The following is a description of a gene set: from publication Xie X, Lu J, Kulbokas EJ, Golub TR, Mootha V, Lindblad-Toh K, Lander ES, Kellis M (PMID 15735639) species: Homo sapiens Genes having at least one occurrence of the highly conserved motif M8 TMTCGCGANR in the regions spanning 4 kb centered on their transcription starting sites. The motif does not match any known transcription factor binding site. Comprehensive identification of all functional elements encoded in the human genome is a fundamental need in biomedical research. Here, we present a comparative analysis of the human, mouse, rat and dog genomes to create a systematic catalogue of common regulatory motifs in promoters and 3' untranslated regions (3' UTRs). The promoter analysis yields 174 candidate motifs, including most previously known transcription-factor binding sites and 105 new motifs. The 3'-UTR analysis yields 106 motifs likely to be involved in post-transcriptional regulation. Nearly one-half are associated with microRNAs (miRNAs), leading to the discovery of many new miRNA genes and their likely target genes. Our results suggest that previous estimates of the number of human miRNA genes were low, and that miRNAs regulate at least 20% of human genes. The overall results provide a systematic view of gene regulation in the human, which will be refined as additional mammalian genomes become available. Human Gene Set: TMTCGCGANR_UNKNOWN, and this is the list of marker genes: UHRF2, THAP7, WDR6 (NCBI Gene Id 55098), ZZZ3, PLOD2, NOL11, PRDX4, PSMB2, RPL26, SMG7, TTC23, ZFP91, SRSF5, PFKFB2, PPP1R12A, COQ9, CCT8, SUPT5H, WDR73, TROAP, IDH3G, RNF167, STXBP4, TMEM209, C5orf24, ASH2L, MARCHF7, COX11, RPS15A, CDK12, NPTN, ZFC3H1, ANKFY1, GGNBP2, PUF60, CHUK, HSPA4, HNRNPK, JOSD2, CD2AP, DCTN2, CENPT, RPL10A, FGFR1OP2, SEPTIN7, WDR44, SMARCD2, SKA3, RBM39, MDH2, CAMK2D, UBE2D3, DGUOK, TMEM79, STYXL1, PSMD5, SAP18, LRRC28, MBTPS1, INO80, EIF5, MPC2, NAA38, LSM14A, ATF2, AGBL3, UPF3B, VDAC3, CDC5L, DBR1, GPATCH3 (NCBI Gene Id 63906), ARF3, DDX3X, INTS13, CRP, RPS19, DNAJC27, GAS8, LAMP1, TAS1R1, FAM76A, QRICH1, THAP7-AS1, ASXL1, RIBC1, KAZALD1, GPBP1, RBM26, ADNP, CYB5D1, NUDT2 (NCBI Gene Id 318), RRAGA, SUV39H1, TMCO1, CHURC1, MAP3K7, CSDE1, TLK2, SLC25A4 (NCBI Gene Id 7872), RPS6, YIPF3, SCAMP5, RPL12, BZW1, CREBZF (NCBI Gene Id 58487), ZNF286A, NFYC, ZNF414, BCAS3, THAP2, DENR, LRSAM1, LUC7L2, PIGN, HNRNPH3, PTPN4, RBPJ, PRDX1, FUS, TSR1, CNOT3, PURA (purine rich element binding protein A), MATR3, THAP1, MAPK14, TTC14, OFD1, SLC12A2, MICU2, ANAPC4, SMC1A, POLR1C, ATP5PB (ATP synthase peripheral stalk-membrane subunit b), RPL17, COX7B, SLC25A11, POLDIP3, MRPL57, NDUFA11, TMEM183A, MMS22L (MMS22 like, DNA repair protein), CAND1, MOB1B, ATF7, NOL9, SEC62, WDR77, IFT74, RAB33B, ICMT-DT, SPAG16, TRAPPC2 (NCBI Gene Id 6399), SSR4, AGL, FSIP1, ZNF346, RPS7, TAOK1, SMG5, BANP, CCNJ, ICMT, MICU3, POU4F1, RMI1, SEC63